Given this list of marker genes Smc3, Esco1, Stag1, Esco2, Rad21, here is a description of the gene set: Reactome Pathway: Establishment of Sister Chromatid Cohesion studied in species Mus musculus This event has been computationally inferred from an event that has been demonstrated in another species.<p>The inference is based on the homology mapping from PANTHER. Briefly, reactions for which all involved PhysicalEntities (in input, output and catalyst) have a mapped orthologue/paralogue (for complexes at least 75% of components must have a mapping) are inferred to the other species. part of: S Phase electronically inferred by orthology from the curated human pathway